The following is a description of a gene set: from publication Chen Y, Wang X (PMID 31504780) Human Gene Set: MIR129_1_3P_MIR129_2_3P studied in species Homo sapiens Genes predicted to be targets of miRBase v22 microRNA hsa-miR-129-1-3p, hsa-miR-129-2-3p in miRDB v6.0 with MirTarget v4 prediction scores > 80 (high confidence targets)., and this is the list of marker genes: GPD1L, RASAL2, N4BP1, KCNB1, CLASP1, YES1, PREP, TLCD5, PRPF39, PKIA, SHISA6, RBMS3, CCDC186, MEMO1, PHTF2, STT3B, USP13, MAP3K1, NALF1, SBK1, SHISA7, UNK, PARP1, ARAP2, EIF3J, C14orf28, E2F5, L3HYPDH, YTHDC2, CALCOCO2, NMNAT2, RTN3, CCP110, ZNF704, POTEC, FAM220A, CAMKK2, MINAR1, FAM120AOS, GNRHR, TIAM1, RIC3, EGLN1, SCN3B, VTI1A, USP32, PTAR1, DLG2, MPZL1, SEC63, DOLPP1, CSRP1, GOLT1B, LHFPL6, KIAA1217, BDKRB2, BIRC6, GPR137C, KRT26, BAG3, HOMER2, CNOT9, FRYL, GRIK4, KPNA4, AZIN1, TRIB1, ROBO1, ZCRB1, NUP98, NPTN, NFATC2IP, DLK1, NR3C1, PRKCE, ERBIN, ACAT2, TMEM64, FMNL2, RCAN2, DGKI, GABRA1, ZBTB44, SEC14L1, FAM124A, WDFY4, ELOVL2, EGLN3, SPRED1, TET3, FRMD3, CPEB1 (NCBI Gene Id 64506), CALN1, USP25, PPP6C, CEMIP2, CHST14, ZNF609, BZW1, KLHL13, MARF1, HECTD1, RHOU (NCBI Gene Id 58480), DYRK3, GPRIN2, BAALC, ABITRAM, LHFPL2, OSBPL10, CCNJ, ILDR2, SYT4, TMEM100, DLGAP4, NFAT5 (nuclear factor of activated T cells 5), RHOBTB1, PHF21A, SACS, HMGCS1, DCAF10, COQ3, RUNX2, SCARF1, ZNF516, RAP2A, SESTD1, H3-3B, MKI67, COLGALT2, IL17A, ABLIM1, TANC2